The following is a description of a gene set: Fanconi anemia (FA) is a genetic disease of genome instability characterized by congenital skeletal defects, aplastic anemia, susceptibility to leukemias, and cellular sensitivity to DNA damaging agents. Patients with FA have been categorized into at least 15 complementation groups (FA-A, -B, -C, -D1, -D2, -E, -F, -G, -I, -J, -L, -M, -N, -O and -P). These complementation groups correspond to the genes FANCA, FANCB, FANCC, FANCD1/BRCA2, FANCD2, FANCE, FANCF, FANCG, FANCJ/BRIP1, FANCL, FANCM, FANCN/PALB2, FANCO/RAD51C and FANCP/SLX4. Eight of these proteins, FANCA, FANCB, FANCC, FANCE, FANCF, FANCG, FANCL, and FANCM, together with FAAP24, FAAP100, FAAP20, APITD1 and STRA13, form a nuclear complex termed the FA core complex. The FA core complex is an E3 ubiquitin ligase that recognizes and is activated by DNA damage in the form of interstrand crosslinks (ICLs), triggering monoubiquitination of FANCD2 and FANCI, which initiates repair of ICL-DNA.<p>FANCD2 and FANCI form a complex and are mutually dependent on one another for their respective monoubiquitination. After DNA damage and during S phase, FANCD2 localizes to discrete nuclear foci that colocalize with proteins involved in homologous recombination repair, such as BRCA1 and RAD51. The FA pathway is regulated by ubiquitination and phosphorylation of FANCD2 and FANCI. ATR-dependent phosphorylation of FANCI and FANCD2 promotes monoubiquitination of FANCD2, stimulating the FA pathway. The complex of USP1 and WDR48 (UAF1) is responsible for deubiquitination of FANCD2 and negatively regulates the FA pathway. <p>Monoubiquitinated FANCD2 recruits DNA nucleases, including SLX4 (FANCP) and FAN1, which unhook the ICL from one of the two covalently linked DNA strands. The DNA polymerase nu (POLN) performs translesion DNA synthesis using the DNA strand with unhooked ICL as a template, thereby bypassing the unhooked ICL. The unhooked ICL is subsequently removed from the DNA via nucleotide excision repair (NER). Incision of the stalled replication fork during the unhooking step generates a double strand break (DSB). The DSB is repaired via homologous recombination repair (HRR) and involves the FA genes BRCA2 (FANCD1), PALB2 (FANCN) and BRIP1 (FANCJ). Homozygous mutations in BRCA2, PALB2 or BRIP1 result in Fanconi anemia, while heterozygous mutations in these genes predispose carriers to primarily breast and ovarian cancer. Well established functions of BRCA2, PALB2 and BRIP1 in DNA repair are BRCA1 dependent, but it is not yet clear whether there are additional roles for these proteins in the Fanconi anemia pathway that do not rely on BRCA1. Heterozygous BRCA1 mutations predispose carriers to breast and ovarian cancer with high penetrance. Complete loss of BRCA1 function is embryonic lethal. It has only recently been reported that a partial germline loss of BRCA1 function via mutations that diminish protein binding ability of the BRCT domain of BRCA1 result in a FA-like syndrome. BRCA1 has therefore been designated as the FANCS gene.<p>The FA pathway is involved in repairing DNA ICLs that arise by exposure to endogenous mutagens produced as by-products of normal cellular metabolism, such as aldehyde containing compounds. Disruption of the aldehyde dehydrogenase gene ALDH2 in FANCD2 deficient mice leads to severe developmental defects, early lethality and predisposition to leukemia. In addition to this, the double knockout mice are exceptionally sensitive to ethanol consumption, as ethanol metabolism results in accumulated levels of aldehydes. part of: DNA Repair studied in species Homo sapiens Reactome Pathway: Fanconi Anemia Pathway, and this is the list of marker genes: EME2, ATRIP, ERCC1, DCLRE1B, EME1, FANCG, FANCD2, RPA1, RPA2, UBE2T, FANCL, UBA52, FANCB, ERCC4, FAAP20, CENPX, FANCM, MUS81 (NCBI Gene Id 80198), UBB, USP1, CENPS, FANCE, FAAP100, SLX4, FAAP24, POLN, UBC, ATR, FANCC, SLX1A, FANCI, FANCA, DCLRE1A, RPS27A, FAN1, FANCF, WDR48, RPA3